The following is a description of a gene set: species: Homo sapiens Catalysis of the phosphorylation and activation of a MAP kinase kinase; each MAP kinase kinase can be phosphorylated by any of several MAP kinase kinase kinases. Human Gene Set: GOMF_MAP_KINASE_KINASE_KINASE_ACTIVITY, and this is the list of marker genes: MAP3K20, MAP3K10, ARAF, MAP3K11, MAP3K12, MAP3K7, BRAF, MAP3K15, MOS, TAOK2, EGFR, MAP3K19, MAP3K4, LRRK2, MAP3K13, MAP3K14, MAP3K5, MAP3K21, MAP3K1, MAP3K8, MAP3K9, RAF1, MAP3K3, RIPK1, MAP3K6, RIPK2, MAP3K2 (mitogen-activated protein kinase kinase kinase 2)